The following is a description of a gene set: Shoulder flexion contracture species: Homo sapiens Human Gene Set: HP_SHOULDER_FLEXION_CONTRACTURE Chronic reduction in active and passive mobility of the shoulder joint due to structural changes in muscle, tendons, ligaments, or skin that prevents normal movement., and this is the list of marker genes: HSPG2, COL12A1, MYL11, MYH3, JAG2, RNU4ATAC, KY, SCN4A, TNNT1